The following is a description of a gene set: Peptide hormone metabolism species: Mus musculus Mouse Gene Set: REACTOME_PEPTIDE_HORMONE_METABOLISM, and this is the list of marker genes: Lhb, Spcs1, Pla2g7, Exoc1, Atp6ap2, Ins1, Ctsz, Exoc3, Exoc4, Inhbe, Ren1, Grp (gastrin releasing peptide), Gng13, Lep, Cma1 (NCBI Gene Id 17228), Cga, Sec11c, Pcsk1, Exoc7, Exoc8, Inha, Gh, Fshb (follicle stimulating hormone beta), Gpr119, Inhbc, Gnat3, Bche, Ffar4, P4hb, Gnb3, Ctsd, Ace, Sec11a, Cpa3, Inhba, Ctsg, Tshb, Exoc2, Agt, Pomc, Inhbb, Slc30a8, Ace2, Gcg, Cpb2, Spcs3, Spcs2, Dpp4, Slc30a5, Enpep, Gnb1, Mboat4, Ghrl, Cpb1, Mme, Ces1d, Ero1b (endoplasmic reticulum oxidoreductase 1 beta), Ffar1 (free fatty acid receptor 1), Exoc5, Gip, Igf1